Given this list of marker genes ATP6V1B2, KCNJ11, AFF4, ALMS1, PIGY, ABCC8, PTCH1, NARS2, KCNN3, KCNH1, TAF1, here is a description of the gene set: Increased thickness of the external ear. Human Gene Set: HP_THICKENED_EARS Thickened ears species: Homo sapiens